The following is a description of a gene set: Catalysis of the hydrolysis of a dipeptide by a mechanism in which water acts as a nucleophile, one or two metal ions hold the water molecule in place, and charged amino acid side chains are ligands for the metal ions. Mouse Gene Set: GOMF_METALLODIPEPTIDASE_ACTIVITY species: Mus musculus, and this is the list of marker genes: Ace, Adam17, Dpep2 (dipeptidase 2), Dpep1, Adam10, Cndp1, Cpq, Mep1a, Cndp2